Given this list of marker genes TRIM71, PTPRF, TRAP1 (NCBI Gene Id 51721), AHCY (adenosylhomocysteinase), FOXA2, EIF6, EBP, MAGED4B, NIPSNAP1, MAGED1, SLC25A1, GALT, SNHG16, SMG5, SEMA4G, MEG3, FASN, C2orf72, GREB1, CENPV, NELFCD, SNORD113-1, IGF2BP2, AK4, ARSL, SREBF2, SNORD114-21, ERBB3, SLC39A5, CLUH, MEG8, SULT1C2, FOXA1, ACACA, SNORD114-20, CHKA, DLK1, DHCR24, SCML2, SNORD114-4, SLC29A4, LRP5, FGFR4, ALDH4A1, USP27X, COASY, TARBP1, ZSWIM5, IGF2BP1, ATP7B, SLC35D2 (solute carrier family 35 member D2), here is a description of the gene set: Background & Aims: Hepatoblastoma (HB) is a rare disease. Nevertheless, it is the predominant pediatric liver cancer, with limited therapeutic options for patients with aggressive tumors. Herein, we aimed to uncover the mechanisms of HB pathobiology and to identify new biomarkers and therapeutic targets in a move towards precision medicine for patients with advanced HB. Genes significantly upregulated in the high-risk Molecular Risk Stratification (MRS-3) hepatoblastoma (HB) as compared with intermediate-risk (MRS-2) and low-risk (MRS-1) molecular HBs, assessed by Human Transcriptome Array (HTA). Human Gene Set: CARRILLOREIXACH_MRS3_VS_LOWER_RISK_HEPATOBLASTOMA_UP species: Homo sapiens from publication Carrillo-Reixach J, Torrens L, Simon-Coma M, Royo L, Domingo-Sàbat M, Abril-Fornaguera J, Akers N, Sala M, Ragull S, Arnal M, Villalmanzo N, Cairo S, Villanueva A, Kappler R, Garrido M, Guerra L, Sábado C, Guillén G, Mallo M, Piñeyro D, Vázquez-Vitali M, Kuchuk O, Mateos ME, Ramírez G, Santamaría ML, Mozo Y, Soriano A, Grotzer M, Branchereau S, de Andoin NG, López-Ibor B, López-Almaraz R, Salinas JA, Torres B, Hernández F, Uriz JJ, Fabre M, Blanco J, Paris C, Bajčiová V, Laureys G, Masnou H, Clos A, Belendez C, Guettier C, Sumoy L, Planas R, Jordà M, Nonell L, Czauderna P, Morland B, Sia D, Losic B, Buendia MA, Sarrias MR, Llovet JM, Armengol C (PMID 32240714)